Given this list of marker genes GSK3A, SLC2A13, RTN1, MIR24-1, EPHA4, IFNG, CLU, ABCG1, APOE, APH1A, BACE1, MIR206, MIR29A, GGA3, CSNK1E, MIR298, ABCA7, MIR15B, NCSTN, ROCK2, SP1, PSENEN, SPON1, MIR16-1, DYRK1A, MIR339, IFNGR1, APH1B, IGF1, LRRTM3, ROCK1, RTN2 (NCBI Gene Id 6253), TNF, TMED10, MIR361, MIR29C, CHRNA7, NTRK2, RELA, ABCA2, CASP3, EFNA1, MIR186, HAP1, MIR103A1, MIR153-1, BIN1, RTN4, PIN1, APOA1, MIR29B1, GSAP, PSEN1, PICALM, PRNP, RTN3, MIR455, SORL1, MIR15A, PSEN2, here is a description of the gene set: The generation of amyloid-beta by cleavage of the amyloid precursor protein (APP). studied in species Homo sapiens Human Gene Set: GOBP_AMYLOID_BETA_FORMATION